Given this list of marker genes Trp53inp1, Rfc5, Ccna2, Top3a, Kat5, Rmi2, Rpa2, Prkag2, Prkaa1, Atm, Chek1, Bard1, Atrip, Blm, Mdm2, Rfc2, Chek2, Tbp, Hus1, Trp53, Nbn, Rfc4, Noc2l (NCBI Gene Id 99992), Prkag1, Taf7, Taf9b, Taf2, Rbbp8, Brip1, Cdk2, Hipk1, Taf1, Uba52rt, Ubc, Rad17 (RAD17 checkpoint clamp loader component), Aurkb, Brca1, Mdm4, Csnk2a2 (casein kinase 2, alpha prime polypeptide), Ccna1, Taf4, Exo1, Prkab1, Taf10, Trp53rkb, Rps27a, Tpx2, Ak6, Taf4b, Ubb, Stk11, Dyrk2 (dual-specificity tyrosine phosphorylation regulated kinase 2), Taf5, Nuak1, Rpa1, Hipk2, Csnk2a1, Prkag3, Taf3, Csnk2b, Taf11, Rad1, Supt16, Uba52, Mapkapk5, Rad9b, Pin1, Taf12, Dna2, Mapk11, Rhno1, Taf15, Prkaa2, Cdk5, Wrn, Mapk14, Rfc3, Rmi1, Prkab2, Rad50, Taf13, Taf9, Rpa3, Taf6, Plk3, Aurka, Topbp1, Ssrp1, Rad9a, Cdk5r1, Mre11a, here is a description of the gene set: species: Mus musculus Regulation of TP53 Activity through Phosphorylation Mouse Gene Set: REACTOME_REGULATION_OF_TP53_ACTIVITY_THROUGH_PHOSPHORYLATION